Given this list of marker genes ACTL7A, CEP112, CCIN, CFAP58, CFAP74, GGN, FBXO43, USP26, FKBP6, C2CD6, WDR19, CATIP, CYLC1, TTC21A, SUN5, BRWD1, ACTL9, DRC1, IQCN, BRDT, KCNU1, SSX1 (NCBI Gene Id 6756), DNAH17, GBA2, ZPBP, TTC29, FSHB, SEPTIN12, STK33, FSIP2, CFAP91, LRRC23, CCDC146, KLHL10, ACR, CFAP44, SPEF2, CFAP65, CFAP69, DNHD1 (dynein heavy chain domain 1, NCBI Gene Id 387750), CCDC34, CFAP43, CFAP70, IFT74, DZIP1, AKAP3, ARMC2, CFAP61, TSGA10, CATSPER2, NANOS1, DNALI1, DNAH8, AK7, AURKC, CFAP47, CCDC62, DNAH1, TEKT3, DNAH7, PPP2R3C, QRICH2, CT55, PMFBP1, DNAH10, SPACA1, DNAH2, SPATA16, STRC, DPY19L2, CDC14A, CFAP251, here is a description of the gene set: Any structural anomaly of a reproductive cell. Abnormal germ cell morphology studied in species Homo sapiens Human Gene Set: HP_ABNORMAL_GERM_CELL_MORPHOLOGY